Given this list of marker genes COLEC11, MCOLN1, RAF1, CHRNG, CANT1, GPC4, GPC3, KRAS, RIT1, COL3A1, NRAS, SLC25A24 (solute carrier family 25 member 24), BRAF, RRAS2, RMRP, SPRED2, PTPN11, RASA2, SOS2, ATP7A, CD96, FBN1, CHRM3, SKI, ACTG2, XYLT1, CSGALNACT1, RRAS (NCBI Gene Id 6237), DIS3L2, LZTR1, FLNB, SOS1, MYH3, MANBA, CBL, MRAS, here is a description of the gene set: Absence or underdevelopment of the abdominal musculature. Aplasia/Hypoplasia of the abdominal wall musculature species: Homo sapiens Human Gene Set: HP_APLASIA_HYPOPLASIA_OF_THE_ABDOMINAL_WALL_MUSCULATURE